Given this list of marker genes KCNK2, TMEM87A, TMEM63B, KCNK10, PIEZO1, KCNK4, NALF2, NALF1, TRPV4, TMEM150C, PIEZO2, here is a description of the gene set: species: Homo sapiens Enables the transmembrane transfer of a monoatomic cation by a channel that opens in response to a mechanical stress. Human Gene Set: GOMF_MECHANOSENSITIVE_MONOATOMIC_CATION_CHANNEL_ACTIVITY